Given this list of marker genes Il6, Hif1an, Gabra6, Yod1, Gramd2b, Fnip1, Cldn12, Grid2ip (glutamate receptor, ionotropic, delta 2 (Grid2) interacting protein 1), Stx17, Rasgrp1, Limk2 (NCBI Gene Id 97744), Soat2, Rbpj, Ddx19b, Mxd1, Dcaf15 (DDB1 and CUL4 associated factor 15, NCBI Gene Id 212123), Zfp975, Katnbl1, Ppargc1b, Dusp22, Ptafr, Pbx1, Gpatch3, Rdx, Plpp6, Rbfox2, Zc3hav1l, Kctd21, Trhde, Trim41, Ppp2r2a, Plpp5, Igf1r, Gxylt1, Pik3ip1, Zbtb39, Col4a1, Faxc, Tet3, 2310022A10Rik, Limd2, Usp24, Smim3 (NCBI Gene Id 79406), Fbxl12, Cemip2, Slc22a23, Tmod2, Casp3, Mroh6, Ints6l, Gpr156, Hectd2, Brd3, Has2, Arhgap28 (NCBI Gene Id 268970), B3gnt7, Pcdh20, Mycn, Ddi2, Psd3, 9930012K11Rik, Pappa, Txlng, Dmd, Alg11, Arid3c, Tmem198b, Pard6b, Slc38a9, Arl5a, Begain, Styk1, Pbx3, Gng5, Gatm, Cpeb1, Cdc34, Liph, Usp38, Hand1, Kif21b, Eea1 (NCBI Gene Id 77935), Snn, Klf8, Sall3, Nol4l, Arhgef15, Cnot6l, Rgs16, Igf2bp2, Stard13, P4ha2, Rfx6, Syt11, Tmco1, Eef2k, Pla2g3, Zfp275, Frmd4b, Cpa4, Sowaha, Rspo2, Galnt2, Slc6a1, Prtg, Intu, Lgr4, Fndc3a, Lpgat1, Leprotl1, Slc35d2 (solute carrier family 35, member D2), Nphp3, Tmc7, Asap1 (NCBI Gene Id 13196), Map3k1 (NCBI Gene Id 26401), Pogz, Efhd2, Plekhg6, Tmprss11f, Snx30, Slf2, G6pc2, Apbb3, Atl2, Nme6 (NME/NM23 nucleoside diphosphate kinase 6), Ercc6, Cflar, Hip1, Plekho1, Stk40, Gas7, Map3k2, Nras, Ddx19a, Smug1, Dtx4, Scn11a, Acvr1c, Taf9b, Nynrin, Bach1, Pde12, Tyk2, Arpp19, Zmat4, Fnip2, Impg2, Pitpnm3, Lrig2, Ybey, 1700017B05Rik, Fignl2, Onecut3, Klhl6, Dnaja2, Trim71, Gdf6, Gpatch2, Ppp1r16b, Nap1l1, Abcb9, Nemp1, Il13, Slc7a14, Myorg, Scyl3, Dlc1, Egln2, Igdcc3, Rab11fip4, Cntrl, Dnajc1, Gnptab, Zbtb5, Ngf, Galnt1, Crb2, Rbms2, Tgfbr1, Pxdn, Skil, Thoc2, Cbx5, Vstm5, Bcat1, Map4k3, Stxbp5, Fam174a, Rgs6, Cbx2, Kif2b, Rab8b, Pald1, Ttll4, Ap1s1, Arid3a, Ccdc71l, Ltn1, Nipal4, Prpf38b, Dna2, Pcgf3, Hdlbp (high density lipoprotein (HDL) binding protein), Slc20a1, Cep135, Tmprss2, Kctd17, Ccr7, Lipt2, Mapk6, Trim6, Cd200r1, Greb1l, Col3a1, Fam135a, Dusp1, Acat1, Igf2bp1, Xkr8, Adrb2, Ccnj, Zswim5, Fgf11, Sigmar1, Slc25a27, Arhgap12, Atp2a2, Slc66a1, Lin28b, Pbx2, Slc2a12, Thoc1, E2f5, Onecut2, Lrig3, Rictor, Fign, Bzw1, P2rx1, Hoxa1 (homeobox A1), Prrx1, Sestd1 (SEC14 and spectrin domains 1), Fasl, Tbkbp1, Fndc3b, Pcdh19, Adamts15, Igdcc4, Trabd, Dnase1l2, Tmem65, D630045J12Rik, Agap1, Macf1, Dtx2, Nek3, Cpeb2, Homer2, Entrep2, Mllt10, Cgnl1, Stx3, E2f2 (E2F transcription factor 2), Lin28a, Sec16b, E2f6, Clasp2, Tspan5, Ehhadh, Sall4, Bsn, Pacs2, Slc10a7, Rufy3, Hmga2, Ndst2, Gcat, Coil, Alox8, Map4k4, Wnt9a (NCBI Gene Id 216795), Igf2bp3 (NCBI Gene Id 72471), Zfp282, Clp1, Slc25a24, Col5a2, Hook1, Brwd1, Cercam, Peg10, Zfp583, Masp1, Dpp3, Plekha8, Fgd6, Stimate, Adamts8, Mfsd4a, Arid3b, Cep120, Senp2, Col4a2, Ints2, Prkaa2, Plxnd1, Zfp512b, Tgfbr3 (transforming growth factor, beta receptor III), Mdfi, 5031439G07Rik, Edn1, Tnfaip8l3, Col27a1, Mapk8, Adamts12, Thrsp, Wasl, Ahctf1, Wdfy3, Tgds, Lbr (lamin B receptor), Fras1, Adrb3, Mdm4, Etnk2, Gpcpd1, Osmr, Trim67, Utrn, Col1a2, Smarcad1, Klk10, Wnt9b, Plxnc1, Zfyve26, Elp1, Hic2, Nr6a1, Cry2, Mycbp, Ccnd2, Gga3, Kdm3a, Diaph2, Slc16a14, here is a description of the gene set: Mouse Gene Set: LET_7I_5P from publication Chen Y, Wang X (PMID 31504780) species: Mus musculus Genes predicted to be targets of miRBase v22 microRNA mmu_let_7i_5p in miRDB v6.0 with MirTarget v4 prediction scores > 80 (high confidence targets).